Given this list of marker genes CA4, PRX, SERPINB6, TUBA1A, EMP2, IL1RL1, ADIRF, ANXA3, TSPAN12, CARD16, CAPZA2, S100A4, TYMP, MYLK, MARCKS, SGK1, CD82, SERPINB1, SPARCL1, ACE, SOSTDC1, TMEM100, EMCN, TSPAN15, HLA-DQB1, DNAJC1, TMEM204, DEPP1, NHERF2, CAV2, ITM2A, SERPINE1, IL32, S100A3, FRY, SLC14A1, CYP3A5, ICAM2, FENDRR, HLA-DMA, RPN1, LGALS1 (galectin 1), APP, HLA-DQA1 (NCBI Gene Id 7946), EDNRB, GNG11, HPGD, SPARC, CNN3, ANXA1, here is a description of the gene set: from publication Gavish A, Tyler M, Greenwald AC, Hoefflin R, Simkin D, Tschernichovsky R, Galili Darnell N, Somech E, Barbolin C, Antman T, Kovarsky D, Barrett T, Gonzalez Castro LN, Halder D, Chanoch-Myers R, Laffy J, Mints M, Wider A, Tal R, Spitzer A, Hara T, Raitses-Gurevich M, Stossel C, Golan T, Tirosh A, Suvà ML, Puram SV, Tirosh I (PMID 37258682) In this study, an extensive analysis was conducted to define meta-programs (MPs) capturing intra-tumor heterogeneity across a spectrum of tumor types. The approach utilized non-negative matrix factorization (NMF) to analyze each cell type separately within individual tumor samples. This involved the analysis of malignant cells, macrophages, fibroblasts, endothelial cells, epithelial cells, T-cells, and B-cells. NMF was executed with varying parameter values (K=4, 5, 6, 7, 8, 9), thereby generating 39 programs for each cell type per sample. Each NMF program was summarized by the top genes based on NMF coefficients.\nRobust MPs were then delineated for each cell type using a set of stringent criteria, including recurrence within the same tumor, similarity to programs in other tumors, and non-redundancy within a tumor. Subsequently, these robust NMF programs were clustered (per cell type) based on Jaccard similarity, leading to the identification of MPs associated with each cell type.\nTo enhance the quality of the MPs, a refinement steps were undertaken, involving the removal of MPs suspected of reflecting low-quality data (with an overrepresentation of ribosomal proteins or mitochondrial-encoded genes), single-study inclusion, or similarity to miss-annotated cell types. Human Gene Set: GAVISH_3CA_METAPROGRAM_ENDOTHELIAL_ENDO_6 studied in species Homo sapiens Genes upregulated in subsets of cells of a given type within various tumors